Given this list of marker genes Abhd17a, Gbp2, Trim15 (NCBI Gene Id 69097), Kcnk13, Ddx3x, Nagk, Ifi207, Btk, Riok3, Ifi208, Flot1, Slc15a4, Dhx58, Sqstm1, Tkfc, Gm12250, Rnf170, Erbin, Cd300lf, Zdhhc3, Zdhhc1, Rnf115, Wdfy1 (NCBI Gene Id 73607), Tab1, Mfhas1, Zdhhc18, Trim32, Lgr4, Stmp1, Sec14l1, Tlr9, Ptprs, Brcc3dc (BRCA1/BRCA2-containing complex, subunit 3, domain containing), Hspa8, Irf4, Tax1bp1, Trim30a (NCBI Gene Id 20128), Bpifb1, Nfkbil1, Pum2, Pum1, Akt1, Ninj1, Igtp, Aurkb, Esr1, Gbp5, Lyplal1, Cd36, Otud4, Gdi1, Usp50, Irak3, Brcc3, Lrrc14, P2rx7, Ptgs2os, Rtn4 (NCBI Gene Id 68585), Eif2ak2, Ppp6c, Tlr1 (NCBI Gene Id 21897), Cptp, Treml4, Map3k7, Rsad2, Tlr6 (NCBI Gene Id 21899), Zdhhc5, Nlrp6, Ppp2ca, Sirt2, Tlr4, Tyro3, Arrb2, Cyba, Ifi203, Lrch4 (leucine-rich repeats and calponin homology (CH) domain containing 4), Fbxl2, Prkdc, Oasl1, Ifi35, Csnk1a1 (casein kinase 1, alpha 1), Irgm1, Cd300ld3, Itch, Gramd4, Zdhhc12, Hspa1b, Parp1 (NCBI Gene Id 98479), Lyn, Trim31, Nr1h3, Mapk8, Irf7, Nlrx1, Tnfaip3, Myd88, Nr1d1, Ifi206, Irgm2, Lats1, Hcfc2, Dhx33, Znrf1, Appl1, Peli3, Peli1, Ogt, Nlrc3, Ifi209, Pik3ap1 (NCBI Gene Id 83490), Ifi213, Tarbp2, Pja2, Src, Acod1, Cd300a, Sarm1, Mndal, Cd14, Nploc4, Ufd1, Smpdl3b, App, Ywhae, Slc46a2, Tspan6, Tasl, Trim3, Slc15a2, Banf1, Gpatch3, Appl2, Ccdc134, Rnf125, Cav1, Aars2, S100a9, Tirap, Pdpk1, Plcg2, Ubqln1, Zdhhc9, Gps2, Prkd1, Trex1, Dab2ip, Pik3r1, Mefv, Ankrd17, Ifi214, Ddx60, Mark4, Ifi203-ps, Rab7b, Trim11, Casp4, Ppt1, Nop53, Slc19a1, D1Pas1, Lats2, Hmgb1, Irf1, Pcbp2, Mavs, Cactin, Lbp, Ptpn22, Slc15a3, Arf6, Atat1, Nek7, Nod2, Ltf, Cgas, Gfi1, Zc3hav1, Usp15, C1qbp, Usp17le, Ticam2, Trem2, Spsb3, F2rl1, S100a8, Znrf4, Zcchc3, Gpr108, Smpdl3a, Lamp2, here is a description of the gene set: Mouse Gene Set: GOBP_REGULATION_OF_PATTERN_RECOGNITION_RECEPTOR_SIGNALING_PATHWAY species: Mus musculus Any process that modulates the rate, frequency or extent of a pattern recognition receptor signaling pathway.